Given this list of marker genes Rfc5, Col2a1, Adamts17, Ppp1r14c, Tfeb, Map6, Kmt5c, Pgam5, Tet3, B4galt2, Clec2g, Dynlt1a, Psen2, Rapgefl1, Iqschfp, Dgkd, Galk1, Edaradd, Ireb2, Stt3a, Zmiz1, Col4a5, Trim9 (tripartite motif-containing 9), Ppp1cb, Col7a1, Wwtr1, Elf2, Plekhd1, Gnao1, Adamts9, Smurf2, Ppic, Kdm4b, Fgd6, Sestd1, Bltp3a, Nexmif, Col5a1, Tet2, Nfatc3, Igf1, Fyn, Trib2, Jazf1, Afap1l1, Serf1, Zbtb34, Col5a3, Clock, Gas7, Clec2i, Ky, Col5a2, Gpr161, Bach2, Rnf19a, 4921524J17Rik, Pcdhb19, Ifi30, Apc2, Gng4, Fstl1, Kif26a, Nmrk1, 2410004B18Rik, Col3a1, Ccny, Tll1 (NCBI Gene Id 21892), Nkiras2, Ube2h, Col4a1, Rab33b, Col6a3, Serpinh1 (NCBI Gene Id 12407), Med26, Zfp282, Sparc, Mrpl1, Cdk6, Phlpp2, Rab30, Reps2, Dnmt3b, Gbp7, Pramel39-ps, Nfat5, Pxdn, Fem1b, Robo1, Atad2b, Macroh2a2, Ankrd13b, Calcr (calcitonin receptor), Dock11, Wnk1, Ralgps1, Klhl28, Adamts7, D630045J12Rik, Clec2d, Opn3, Nudt16l1, Traf3, here is a description of the gene set: Genes predicted to be targets of miRBase v22 microRNA mmu_miR_3102_3p in miRDB v6.0 with MirTarget v4 prediction scores > 80 (high confidence targets). species: Mus musculus Mouse Gene Set: MIR_3102_3P from publication Chen Y, Wang X (PMID 31504780)